Given this list of marker genes UBE2L3, DENND11, ARHGEF10L, SLAIN1, CAPN7, GCH1, CDKN1A, DPY19L4, PTER, GOLPH3, TRAF4, CLGN, GALK2, RPAIN, GABRB3, MLLT3, CTBP2, PBRM1, MCM3AP, AMN1, TNFAIP8, TRAF3IP1, MTBP (NCBI Gene Id 27085), WRAP73, OR2T33, REEP1, CCDC88A, PGS1, FAM20B, PLRG1, ACTR6, PPP1R26, RNF19A, MTFR2, TES, SERPINE2, LUC7L3, MLLT11 (MLLT11 transcription factor 7 cofactor), TIA1, ULK4, FLG, STK3 (serine/threonine kinase 3), IL4I1, DEPDC1, KIF6, ATP1B4, PTS, REPIN1, PCDHGC4, PHKB, PIERCE1, RYR2, JAK1, VPS29, UBE2B, BCOR, DPCD, TBC1D1, TPD52, PRDX2, KAT7, CBY2, DAW1, TRPM4, GRK6, AGPAT4, SUPT7L, UBASH3B, SLC7A13, PWWP4, KRIT1 (KRIT1 ankyrin repeat containing), MRPS21, INTS12, BLOC1S2, ACSBG2, CSAD, RDM1, NQO2, FAHD1, ZFP69, HOOK3, REST, NAXE, NIPSNAP3B, FARS2, CTXN3, CEP290, TEKT1, TMEM107, ATP5F1A, C18orf54, ESRP2, GADD45A, STK17B, USP34, SQSTM1, RHOH, ITGB3BP, BIVM, MPP7, TEX48, DISP3, MRPL10, MMP11, DCDC2C, HASPIN, SEC61A2, H1-0, HBP1, IGF2R, ANAPC16, KIF20A, PMCH, GNB4, LAGE3, MAT1A, SAC3D1, KLF10, HOOK2, MED14, ZNF365, HAP1, PRPF38B, MAP4, TCF12, MAP3K2, SIRT3, OMA1, XPR1, ITM2C, PHACTR4, NR4A3, LGMN, CCDC39, PXMP2, SENP7, CYP39A1, L3MBTL3, TUBA1A, CEP89, UCK1, CCNB2, FAM81A, NIPSNAP1, OSBPL11, FUT1, MXD1 (MAX dimerization protein 1), PRC1, GALNT4, PIAS3, ANKRD46, CHEK2, SLC25A40, DEXI, PIGX, VBP1, GADD45B, NUMA1, TMEM35B, XIAP, TTC21A, COG6, NIPBL, ZNF546, CNN3 (calponin 3), EGLN2, GOLGA4, LSM14A, BPNT1, PPP1R17 (NCBI Gene Id 10842), ZNF878, DIP2B, IQGAP3, NIPAL3, CEP55, PRR9, LAMA3, SOS2, LCN12, BLOC1S5 (NCBI Gene Id 63915), TINF2, SAMSN1, VPS4A, WDR91 (WD repeat domain 91), COL18A1, PDE6D, S100A11, FAM216A, EHMT2, GJA4 (gap junction protein alpha 4), ASB3, RNF215, TRMT1L, DMP1, GNAT1, SPC25, PPP2R5C, PON2, TNFAIP3, NTAQ1, here is a description of the gene set: Human Gene Set: GSE46606_DAY1_VS_DAY3_CD40L_IL2_IL5_STIMULATED_IRF4_KO_BCELL_DN Genes down-regulated in CD40L and IL-2 IL-4 IL-5 stimulated at day 1 B cell IRF4-KO versus CD40L and IL-2 IL-4 IL-5 stimulated at day 3 B cell IRF4-KO. from publication Ochiai K, Maienschein-Cline M, Simonetti G, Chen J, Rosenthal R, Brink R, Chong AS, Klein U, Dinner AR, Singh H, Sciammas R (PMID 23684984) studied in species Homo sapiens Temporal analysis of B cell activation in vitro using CD40L and IL-2/4/5 cytokines in wild type Irf4+/+ B cells or in mutant Irf4-/- B cells harboring a tet-inducible allele of Irf4. IRF4 expression was restored, or not, in the Irf4-/- background by culturing in the presence of low or high concentrations of doxycycline. The results provide insight in the role of IRF4 expression levels in coordinating different programs of B cell differentiation.